The following is a description of a gene set: Mouse Gene Set: GOBP_TRIGEMINAL_NERVE_MORPHOGENESIS species: Mus musculus The process in which the anatomical structure of the trigeminal nerve is generated and organized. The trigeminal nerve is composed of three large branches. They are the ophthalmic (V1, sensory), maxillary (V2, sensory) and mandibular (V3, motor and sensory) branches. The sensory ophthalmic branch travels through the superior orbital fissure and passes through the orbit to reach the skin of the forehead and top of the head. The maxillary nerve contains sensory branches that reach the pterygopalatine fossa via the inferior orbital fissure (face, cheek and upper teeth) and pterygopalatine canal (soft and hard palate, nasal cavity and pharynx). The motor part of the mandibular branch is distributed to the muscles of mastication, the mylohyoid muscle and the anterior belly of the digastric. The mandibular nerve also innervates the tensor veli palatini and tensor tympani muscles. The sensory part of the mandibular nerve is composed of branches that carry general sensory information from the mucous membranes of the mouth and cheek, anterior two-thirds of the tongue, lower teeth, skin of the lower jaw, side of the head and scalp and meninges of the anterior and middle cranial fossae., and this is the list of marker genes: Sema3f, Nrp1, Plxna3, Sema3a, Plxna4